The following is a description of a gene set: Any process that modulates the frequency, rate or extent of N-methyl-D-aspartate selective glutamate receptor activity. Mouse Gene Set: GOBP_REGULATION_OF_NMDA_RECEPTOR_ACTIVITY species: Mus musculus, and this is the list of marker genes: Rasgrf2, Mapk8ip2, Nlgn3, Nlgn1, Reln, Oprm1 (opioid receptor, mu 1), Crh, Dapk1, Crhbp, Rasgrf1